The following is a description of a gene set: Mouse Gene Set: REACTOME_FLT3_SIGNALING FLT3 Signaling studied in species Mus musculus, and this is the list of marker genes: Cdkn1b, Syk, Ptprj, Uba52, Pik3ca, Pik3r1, Grap2, Flt3l, Sh2b3, Grb10, Lck (NCBI Gene Id 16818), Sla, Foxo3, Grb2, Sos1, Socs2, Hras, Akt1, Abl2, Rps27a, Uba52rt, Cbl, Ubb, Akt2, Socs6, Kras, Csk, Akt3, Ubc, Sla2